Given this list of marker genes SH3D19, GTF2I, MRPS14, SPAST, ATP2A2, RAP2C, YY1AP1, AFG2A, MAP3K20, BHLHE22, VPS37A, PLOD2 (NCBI Gene Id 5352), GNB4, PPHLN1, CDH8, PRTG, MAPRE1, SRPX2, ADD2, TOP1, SLC22A5, SSH2, NAA40, ZNF254, EEIG2 (EEIG family member 2), LMAN1, SPTLC1, RUNDC3B, STK38L, EIF4EBP1, RBFOX2, CHST2, ARHGEF33, MID1, MBNL1, ANTXR2, SUGP2, PBX1 (NCBI Gene Id 5087), ATG13, CCN4, SS18, ADM, RUVBL1, CLGN, SEC14L4, ANKRD29, PLA2G12B, MRE11, SHOC2, NTRK2, BRWD1, CFAP91, VASP, SLC43A1, PABPN1, CTBP2, MAPRE2, ZNF426, TFAM, RBM15, SS18L2, KATNA1, LPGAT1, CDK5RAP3, TTL, LARP1, ZDHHC3, ANKRD28, ETAA1, LYST, UGT2A1, ABR, ACSL1, NUDT9, DCAF5, CXXC4, RNF182, IGFBP5, NEMP2, RREB1, FBXO40, CRACR2A, DIO2, NR1D2, FZD1, ZNF384, EBF1, UBE4A, ANKRD17, UGGT1, PRRX1, ATP8B2, MAOA, MRPL50, UBE2Q2P13, ANO6, CELSR2, IDNK, ZNF607, UBASH3B, SETX, MED13L, USP34, LHX6, BRINP1 (BMP/retinoic acid inducible neural specific 1), ASPH, ZNF431, TMEM169, ZNF534, CLDN18, MPST, CREG1, XPO7, ARFGEF3 (NCBI Gene Id 57221), MACO1, GLI2, CEP126 (NCBI Gene Id 57562), SLC38A5, MTTP, NRXN3, SPATA31C1, PSMA8, RBM41, CIT, CXorf38, XKR6, GRIP1, ZNF624, TFAP2B (NCBI Gene Id 7021), MED13, DSC3, FN3KRP, HMGXB4, ENPP2, NMNAT1, FAM43A (NCBI Gene Id 131583), MCOLN3, XPO4, EMC3, GOLGA4, RAB3IP, NEMF, SH3TC2, FAM120AOS, CER1, GPR161, PRPS1, PALM2AKAP2, PDCL, CNEP1R1, EEF1A2, ZNRF3, PKHD1, CRCP, XRRA1, ARK2C, GABARAP, CHIC1, HTR1F (5-hydroxytryptamine receptor 1F), AGAP1, CCDC198, HRG, ETS1, MAP4K5, SLFN13, DNMT3A, COMMD3, CDC42, EDNRB, ZSCAN31 (NCBI Gene Id 91921), NRXN2, MIB1, LCP1, TRIM10, NTNG1, RIMS2, YTHDF2, SETD6, ZNF559, VTI1A, RAP1GAP2, GRIA3, MLX, JPH2, WDR76 (WD repeat domain 76), SDHD, MRPL33, NRBF2, DEPTOR (NCBI Gene Id 64798), POMT2, DYNLT1, ATP10D, MTCL3, GSK3B, SOCS5, AP1G1, TNRC6B, ZBTB20, PSD3, VSTM4, PRLHR, NABP1, DCLK1, SPIC, ZNF420, EPM2A, NUDT16, SGMS2, HOXA9, PPP1R15B, ERBB3, RELB, RWDD4, NIBAN1, DPYSL2, IGF2BP2, MAPK10, FSTL5, PPFIA2, IL7R, FOXJ2, ARHGAP9, GSPT1, ABHD10, ZFP30, CSRNP3, CADM2, FBN2, EIF4EBP2, NALF1, CCL15, TCAF1, SENP8, SENP6, EPHA3, CREBBP, SPATA31C2, ZNF521, PIGX, RUNX1T1, EHF, MON2, PTCHD4, ZNF704, LYRM7, ZC3H11A, UGT2A2, CAMK2G, OPRM1, SDC3 (NCBI Gene Id 9672), FGF5, ZNF90, USP38, BLTP3A, ZNF606, NRG3, SREK1, MOSMO, TTI2, HSD17B12, FBLN1, CUL2, FDX1, SYPL2, FZD4, GUCY1A2, PKNOX2, TRMT1L, RBMS3, ADAM22, ZIC2, PCNT, SPTB, IFI27, ZNF326, ANO5 (NCBI Gene Id 203859), GRAP2, FHL1, NR4A3, ADGRL3, OTULIN, RAB33B, ELAVL4, NUFIP2, DNAJB4, UBN2, TMEM207, CNTN3, PPP3R2, ZKSCAN1, TBC1D16, A1CF, CAVIN1, FZD7 (NCBI Gene Id 8324), ERICH1, CRISPLD2, LDLRAD1, ATP10B, NDRG2, KBTBD11, KIF5B, TYW1, TRAF3, GPR180, DIS3, PCLO (NCBI Gene Id 56630), GRIA1, here is a description of the gene set: studied in species Homo sapiens Genes predicted to be targets of miRBase v22 microRNA hsa-miR-3059-5p in miRDB v6.0 with MirTarget v4 prediction scores > 80 (high confidence targets). Human Gene Set: MIR3059_5P from publication Chen Y, Wang X (PMID 31504780)